Given this list of marker genes Cntn2, H3f3b, Fam124a (family with sequence similarity 124, member A), Bean1, 1810010H24Rik, Tfcp2l1, Ythdc2, Slc66a3, Minar1, Eci1, Clasp1, Frmd3, Ppp4r1, Fmnl2, Erbin, Arap2, Nfatc2ip, Zfp704, Rcan2, Rhou, Dgki, Zc3h7b, Ptger4, Dcaf10, Syt4, Fam220a, Azin1, Zdhhc15, Dok4, Zbtb41, Parp1, Bzw1, Zfp609, Mapk3, Smad3, Zmat1, Egln3, Memo1, Stt3b, Nphp3, Rhobtb1, Zbtb44, Aif1l, Usp32, Phtf2, Ift122, Scn3b, Mcur1, Prep, Ccp110, Nmnat2, Tanc2, Tia1, Ssh3, Fryl, Cacna1d, Gabra1, Shisa7, Vti1a, Cptp, Trib1, Nup98, Ppp1r26, Ubr2, Mpzl1, Prkce, Phf21a, N4bp1, Caln1, Tlcd5, Golim4, Tmf1, Plpp3, Hrk (harakiri, BCL2 interacting protein (contains only BH3 domain)), Baalc, Pramel3d, Wdr26, Tmem100, Smc1b, Cemip2, Klhl28, Nwd2, Ado (2-aminoethanethiol dioxygenase), Dolpp1, Snapin, Hnrnpa3, Gm527, Ly6g6e, Zfp516, Krt222, Usp25 (ubiquitin specific peptidase 25), Snx6, Pkia, here is a description of the gene set: Mouse Gene Set: MIR_129_1_3P_MIR_129_2_3P from publication Chen Y, Wang X (PMID 31504780) Genes predicted to be targets of miRBase v22 microRNA mmu_miR_129_1_3p, mmu_miR_129_2_3p in miRDB v6.0 with MirTarget v4 prediction scores > 80 (high confidence targets). studied in species Mus musculus